The following is a description of a gene set: studied in species Homo sapiens Human Gene Set: KEGG_MEDICUS_VARIANT_BCL2_OVEREXPRESSION_TO_INTRINSIC_APOPTOTIC_PATHWAY Pathway Definition from KEGG: BCL2* -| BAX -> CYCS == APAF1 -> CASP9 -> (CASP3,CASP7) BCL2-overexpression to intrinsic apoptotic pathway. Pathway ID: N00100. Pathway type: Variant. Pathway class: nt06267 Small cell lung cancer., and this is the list of marker genes: CYCS, CASP7, BAX, BCL2, CASP9, CASP3, APAF1